The following is a description of a gene set: Mouse Gene Set: REACTOME_EGFR_INTERACTS_WITH_PHOSPHOLIPASE_C_GAMMA EGFR interacts with phospholipase C-gamma studied in species Mus musculus, and this is the list of marker genes: Tgfa, Epgn, Plcg1, Egf, Ereg, Egfr, Btc, Areg, Hbegf